The following is a description of a gene set: Catalysis of the reaction: NAD(P)H + H+ + a quinone = NAD(P)+ + a quinol. Mouse Gene Set: GOMF_NAD_P_H_DEHYDROGENASE_QUINONE_ACTIVITY species: Mus musculus, and this is the list of marker genes: Rtn4ip1, Cbr3, Nqo2, Nqo1, Cbr4